The following is a description of a gene set: studied in species Homo sapiens Eicosanoid metabolism via cytochrome P450 monooxygenases pathway Human Gene Set: WP_EICOSANOID_METABOLISM_VIA_CYTOCHROME_P450_MONOOXYGENASES_PATHWAY, and this is the list of marker genes: PPARA, CYP2C18, CYP4F2, CYP4F12, EPHX2, CYP4A11, CYP4A22, CYP2C8, PPARG